Given this list of marker genes CLIC5, FOXA2, RGS17, PGM1, RBP7, ACAT1, ANGPT1, PUS10, SUPT20H, FZD2, DCLK3, MAP4K2, ATP8A2, WDSUB1, KCNQ1, CCDC160, C6orf136, STARD10, CELF4, ADGRF4, PDHA1, PAQR6, PRKCE, PODN, STC1, SULT1A1, RORC, NECAB1, ANKRD2, RETREG3, PCMTD2, CYP27A1, MTFR1L, MLANA, SHOX2, PFDN1, RASEF, LMOD2, C14orf93, FSD2, ACADM, SVIP, INMT, CD163, FAM221A, PRCD, PDZRN3 (NCBI Gene Id 23024), PCSK6, EPC2, JAKMIP3, HADH, DPYD, DNAJC16, DCAF15, MBIP, CNR1, KCNJ3, CSGALNACT1, EDAR, COQ9, GABRE, CSRP1, KLHL4, PMPCA, HDDC3, FAM163A, NUDT7, PKIA, PAFAH1B1, ASTN1, CPPED1, UQCRFS1, RC3H1, HSPB2, ATP1A2 (ATPase Na+/K+ transporting subunit alpha 2), RECQL4, RYR1, NEXN, MYOC, CACNA2D2, SLC22A13, NR2F1, VSIG4, ALDH1A1, SCN1A, NUDT12 (NCBI Gene Id 83594), PLCH1, MXRA7, PRKAB2, REG1A, PFKM, TPD52L1, ANGPTL7, GSTO1, AXIN2, ASB11 (NCBI Gene Id 140456), CAP2, FYCO1, SLC25A12, FOXRED1, GLI1, TP53I13, KCTD18, CD300LG, SNW1 (SNW domain containing 1), TRIM63, CPXM2, OGDH, NDUFAB1, NOTCH3, ARMH4, PHYH, ETFDH, ECH1, CES1, RGS12, ZNF483, KLHL41, KIAA1549L, SUCLA2, PHF14, ZBTB8B (zinc finger and BTB domain containing 8B), SEPTIN11, EHD4, SGSM1, PRRG3, GRPR, HHATL, FMO1, ATG101, NDUFS1, SMARCA1, KYAT3, PITHD1, PPARA, MSRB2, HELQ, RCAN2, CNTFR, TCP10L, SVEP1, PHF3, SIN3B, PDE7B, DNAJC6, MYBPHL, ACBD4, CXCL13, FBXW10, CAVIN4, MFSD2A, RPS6KA6, GPIHBP1, THOC1, FAM210B, UNC50, TKT (transketolase), ASB14, ADAM22, IRF3, SCG5, FKBP3, TXNDC2, FOXD2, DPEP1, MORN1, ANKRA2, ST6GALNAC6, GATA2, RCOR3, ALDH6A1, CMYA5, CDC73, ISL1, PTN, TCAF2, RWDD3, ATP5F1A, MDH2, MAOB, IVD, MEIKIN, ING3, VAMP5, CDK16, ZFTA, TRAPPC6A, KLHL13, SYCP3, PDP1, GCK, SMS, CHCHD2, SERPING1, GSTA3, NOXO1, RALGPS2, ARNT, CHPT1, PDE7A, here is a description of the gene set: studied in species Homo sapiens Human Gene Set: GSE31622_WT_VS_KLF3_KO_BCELL_UP from publication Vu TT, Gatto D, Turner V, Funnell AP, Mak KS, Norton LJ, Kaplan W, Cowley MJ, Agenès F, Kirberg J, Brink R, Pearson RC, Crossley M (PMID 22003205) Genes up-regulated in splenic B lymphocytes: wildtype versus KLF3 knockout. To investigate the roles of Klf3 in B lymphopoiesis, CD19+ B cells were sorted from the spleens of WT and Klf3 KO mice (Molecular and Cellular Biology (2008); 28:3967–3978). Following RNA extraction, gene expression was compared in WT and Klf3 KO CD19+splenic B cells using Affymetrix microarrays.